Given this list of marker genes EIF2B4, GTF2H3, IQSEC2, PIN1, VAMP5, HINFP, ZMIZ1, MUC6, AQP8, RNF103, ALDH3B1, LAMB3 (laminin subunit beta 3), MYO1F, SREBF2 (sterol regulatory element binding transcription factor 2), CEACAM7, TMEM268, ARR3, ATOX1, TBC1D9, UTRN, AMHR2, POLR2J, RABGGTA, BAG5, BCL2L1, NDUFS6 (NADH:ubiquinone oxidoreductase subunit S6), HIRA, PTGIR, SLC5A4, PTPN4, EDC4, UBN1, CA5B, CYBA, MYO1E, OR7A5, TRAPPC3, PYGM (glycogen phosphorylase, muscle associated), DEGS1, KIAA0232, SUN1, RCBTB2, TCF25, ZW10, NDUFB7, SUSD6, BBS4, RNH1, RNF113A, GRB2, VASH1, ITPA, C15orf39, CD9, SMARCD3, TP53, L1CAM, PIP4K2A, CTDSP2, STK10, FLII, ZNF202, SKAP2 (NCBI Gene Id 8935), AASS, POU6F2, SPINK4, PTPA, ARHGAP45, DLEC1, OVOL3, HSPA9, PDE1A, CHAF1A, CLTB, HPCAL1, MDK, PMF1, DENND5A, SLK, GPS2, EDA, TPST2, TNFRSF14 (NCBI Gene Id 93208), CD33, LY86, IRF7, PDCD11, KRT85 (keratin 85), GAS6, SERPINB13, HELZ (helicase with zinc finger), PCYT2, FLOT2, ERBB2, VPS45, HSPA5, DCHS1, BLTP1, PBX2, SRSF10, LGMN, HTR1E, TMEM184B, VTI1B, CYB5R1, RERE, RHOA, GPR107, CAPN7, SLC1A6, MTMR1, ADA, ERCC1, ARF3, PRKCD (NCBI Gene Id 5580), LIFR, FBXO7, LTA4H, GAK (NCBI Gene Id 2580), PDIA4, CD7, PADI2, PHF20, ITPK1, ASF1A, SMYD5, POLG (DNA polymerase gamma, catalytic subunit), GPAA1, DOCK1, ARHGEF2, ATG9A, RTCA, NDUFS3, NUP133, PTK2B, ACVR1, PTPRE, NRTN, FAM50B, PSMD9, FZD2, CDK16, NAP1L4, LRP10, PROS1, GAS7, SCN9A, TAF12, PPP1R3D, SLC31A2, MGLL, TBCD (NCBI Gene Id 6904), SDHB, LY6E, SH3BP1, REM1, RAE1, GABARAPL2, ATP6V1H, ACOX1, OXA1L, LARP4B, SH2B1, SAMD4A, TESK1, ZNF629, CR2 (complement C3d receptor 2), DAP, CD4 (NCBI Gene Id 920), INPP4B, NR1H3, SPN, PLEKHM2, NAGLU, RAC2, HDDC2 (HD domain containing 2), TBCB, P2RX4, ENTPD6, UBE3C, TMEM63A, FKBP2 (NCBI Gene Id 2286), NUDT21, GTF3C2, TUBA1A, CD99, PPM1B, TNFAIP2, PHYH, IDH1, NRG1, STXBP2, ARSB, FCGBP, SELENOP (NCBI Gene Id 6414), ZNHIT1, SPEN (NCBI Gene Id 348488), MEOX1, APBB3, here is a description of the gene set: species: Homo sapiens from publication Chaussabel D, Semnani RT, McDowell MA, Sacks D, Sher A, Nutman TB (PMID 12663451) Monocyte-derived dendritic cells (DC) and macrophages (MΦ) generated in vitro from the same individual blood donors were exposed to five different pathogens, and gene expression profiles were assessed by microarray analysis. Responses to Mycobacterium tuberculosis and to phylogenetically distinct protozoan (Leishmania major, L. donovani, Toxoplasma gondii) and helminth (Brugia malayi) parasites were examined, each of which produces chronic infections in humans yet vary considerably in the nature of the immune responses they trigger. Genes down-regulated in comparison of macrophages exposed to T. gondii versus macrophages exposed to 5 worms/well B. malayi. Human Gene Set: GSE360_T_GONDII_VS_B_MALAYI_LOW_DOSE_MAC_DN